The following is a description of a gene set: Genes in the cancer module 279. Human Gene Set: MODULE_279 studied in species Homo sapiens, and this is the list of marker genes: ENOX1, DDX17, PPP1R11, VAV2, CISH, TRIP4 (thyroid hormone receptor interactor 4), ZNF292, DHX34, SMARCA5, TRIM33, SNX2, MAD2L2, PNLIPRP1, FUZ, CRBN, CYTH1, SDHC, H2AC18, SINHCAF, CEBPD, ACSL3 (acyl-CoA synthetase long chain family member 3), CCT6A (NCBI Gene Id 908), AKAP5, ATE1, COL4A5, RERE, PCCB (NCBI Gene Id 5096), MCTS1, CYRIA, HLA-DPA1, YPEL3, HSPA1B, CARD16, FGF13, PFKFB3, GRIN2C, NUMA1, GABRE, GCHFR, SYNGR1, DNAJC9, SRPRB (SRP receptor subunit beta), DUSP4, DMD (NCBI Gene Id 548327), DLX5, PRSS1, DPP6, HS6ST1, MYO5B, NOL7, DCAF10, PYROXD1, PTHLH, GAS2, DDX11, CLSTN3, LHX3, NDP, FRMD4A, GTPBP3, PRKAR2B, BMP6, LEP, ZNF224, TFAP2B, TGFB3, RDX, ATG16L1, AK3, FLVCR1, PRG2 (NCBI Gene Id 87065), PTPRS, ESYT2, ERCC3, PLPP3, PCTP, LGALS8, HOXD8 (homeobox D8), ZNF587, CXCL10, GALC, PILRB, FERMT2, THEMIS2, OSGIN2, AAGAB, GCLM, BOD1L1, FOSL2, BET1L, TIMP1, RPS18 (ribosomal protein S18), MBD5, DSG2, SYT1, SPOCK2, SNED1, NUP210, IFI35, MAP3K2, DHRS3, BHLHE41, ARPC5, MIEN1, KIF13A, LBP, DDX18, SP110, NFATC4, SIL1, KCND1, PLCL1, RPS5, CCNB1, TMEM143, SERPINA3, LZTR1, RPL24, CCNG2, BPHL, LIMK2, FRG1, AP1S1, SOX2, ZEB1, PSEN1 (NCBI Gene Id 5663), PMS2P1, MAP3K10, OSBPL2 (oxysterol binding protein like 2), S100A12, WNT3A, NBPF3, SLC12A4, DNAAF8, MAP4K2 (NCBI Gene Id 5871), PSMA3, RPL13, GEMIN7, SKIC2, KRT19, ANXA4